The following is a description of a gene set: species: Homo sapiens from publication Amit I, Garber M, Chevrier N, Leite AP, Donner Y, Eisenhaure T, Guttman M, Grenier JK, Li W, Zuk O, Schubert LA, Birditt B, Shay T, Goren A, Zhang X, Smith Z, Deering R, McDonald RC, Cabili M, Bernstein BE, Rinn JL, Meissner A, Root DE, Hacohen N, Regev A (PMID 19729616) mouse primary BMDCs were stimulated with tlr ligands and gene expression changes were profiled on Affymetrix arrays Human Gene Set: GSE17721_PAM3CSK4_VS_CPG_4H_BMDC_UP Genes up-regulated in comparison of dendritic cells (DC) stimulated with Pam3Csk4 (TLR1/2 agonist) at 4 h versus DC cells stimulated with CpG DNA (TLR9 agonist) at 4 h., and this is the list of marker genes: MPZL2, FANK1, MFAP1, MAPK7, ORM1, ACOT8, TMEM14C, ARIH2, IFRD1, MARCHF6, PRG4, ITGA8, CREB3, UBP1, LSS, KLF10, POT1, ZNF322, VPS13C, C11orf91, NISCH, TEPSIN, SACS, RFC1, SNX17, TSPAN14, PBDC1, HAX1, CSF1R, TMUB2, SLC19A2, HACD3, SEC61B, SMIM12, FCHO1, AMPD2, IMP3, ACVR1B, SIRPA, ADCY7, SARAF, KATNBL1, FAM89B, EMC7, SLC22A5, HYCC2, INPP5D (NCBI Gene Id 653796), MATN1, COTL1, EIF5, TMEM120B, SASH3, HMGCS1, FAM120A, SECISBP2, UBE2V1, EHBP1L1, MEF2D, TFEB, DENND2D, COLGALT1, P2RY6, YWHAQ, PWP2, CACNA2D3 (calcium voltage-gated channel auxiliary subunit alpha2delta 3), PTDSS2, H2AX, CD14, NELFB, RABGGTB, ZNF638, SRSF1, NPEPL1, NSDHL, HDHD5, PIP4K2C, RIOK3, HS1BP3, DNMT3L, ATF4, SGMS1, ATP6V0C, TET1, CDC42SE1, ETFBKMT, SMDT1, FERMT3, SLC26A4, PPP1R21, BBLN, UNC119B, FKBP15, ADORA1, DUSP1, MEPCE, IFNGR1 (interferon gamma receptor 1), FAM50A, ANKH, ZBTB1, HNRNPH3, PIM3, IFNGR2, ACO1, CHMP1A, ZFP36L1, TMA16, MAT2A, RANBP10, SMARCAL1, VDAC1, KIF1C, NBR1, ATP5MC3, DOCK7, PTPA, ZNF830, TNPO3, TMBIM4, SRXN1, APPL2, RIC8A (NCBI Gene Id 60626), APRT, CAV3, CLN8, YY1, HYCC1, WDR6, DDX42, CALR, GNPDA1, TUBB2A, CHPF, RCOR1, METAP1, NECAP2, EFNB2, TACC2, ZKSCAN1, NDUFC2, PEA15, OR8A1, ZFP36L2, SLX9, SIAH1, C7orf25, CPS1, QNG1, FEM1A, OPN3, DNMT3B, ARMC10 (armadillo repeat containing 10), TMEM101, ARF1 (ADP ribosylation factor 1), ULK2, POR, NDEL1, TCF3, NCOR2, FAM13B, MYADM, KDM3A, GLUD1, HNRNPDL, INTS6L, LAMTOR3, TMEM165, ZMYND8, BIN3, PLP2, HNRNPF, CCNH, ELP1, ZNF600 (zinc finger protein 600), SRP9, RAN, MAK16, ARHGAP1, CPEB2, CREBZF, PLEKHO1, ENDOG, MRPL44, AARS1, DNAJC3, ADAM8, PPP5C, ORMDL1, TBX5, BATF3, SP4, NOPCHAP1, RBM25, SFT2D1, CDC34, PELO, LASP1, SPICE1 (spindle and centriole associated protein 1), OIT3, JAM2, GDAP2